Given this list of marker genes Sugt1, Cav2, Fos, Ppard, Mstn, Snhg15, Cflar, Rtl1, Fgf2, Myog, Six1, Ephb1, Stat3, Megf10, Hgf, Kpna1, Angpt1, Sirt1, Akirin1, Dsn1, Selenon, Jak2, Six5, Src, Shh, Paxbp1, Ndc80, here is a description of the gene set: Mouse Gene Set: GOBP_SKELETAL_MUSCLE_CELL_PROLIFERATION The multiplication or reproduction of skeletal muscle cells, resulting in the expansion of a cell population. species: Mus musculus